Given this list of marker genes MIR33A, ABCB11, CES1, CLDN2, TNF, here is a description of the gene set: Any process that modulates the frequency, rate or extent of the controlled release of bile acid from a cell or a tissue. Human Gene Set: GOBP_REGULATION_OF_BILE_ACID_SECRETION species: Homo sapiens